Given this list of marker genes BNIP3L, NDRG2, NAPRT, SLC2A6, SLC47A1, EMILIN2 (elastin microfibril interfacer 2), EIF2AK4, HEATR3, CPEB3, CTBP1, ITGAL, HBZ, ASGR2, ADSS1, BIRC3, GPR18, ALDH16A1, PRAM1, EIF4G3, MEF2A, SLC39A11, HBA1, ULK2, FBXO15, MYL4 (myosin light chain 4), ZEB1, SLC25A13 (solute carrier family 25 member 13), SAT2, NANS, SPON2, C8orf82 (NCBI Gene Id 414919), DEFA4, ACKR3, ZSWIM5, DCAF12, TMOD1, HBB, here is a description of the gene set: species: Homo sapiens Genes that are components of a model predictive of response in peripheral blood mononuclear cell 7d vs 0d in adults (18-45) after exposure to YF-17D vaccine, time point 7D. Comment: Suppl Table 4: genes validated by ClaNC as being predictive of CD8+ T cell responses from Fig. 4. from publication Querec TD, Akondy RS, Lee EK, Cao W, Nakaya HI, Teuwen D, Pirani A, Gernert K, Deng J, Marzolf B, Kennedy K, Wu H, Bennouna S, Oluoch H, Miller J, Vencio RZ, Mulligan M, Aderem A, Ahmed R, Pulendran B (PMID 19029902) Human Gene Set: QUEREC_MODEL_PBMC_YF_17D_VACCINE_AGE_18_45_7DY_PREDICTIVE A major challenge in vaccinology is to prospectively determine vaccine efficacy. Here we have used a systems biology approach to identify early gene 'signatures' that predicted immune responses in humans vaccinated with yellow fever vaccine YF-17D. Vaccination induced genes that regulate virus innate sensing and type I interferon production. Computational analyses identified a gene signature, including complement protein C1qB and eukaryotic translation initiation factor 2 alpha kinase 4-an orchestrator of the integrated stress response-that correlated with and predicted YF-17D CD8(+) T cell responses with up to 90% accuracy in an independent, blinded trial. A distinct signature, including B cell growth factor TNFRS17, predicted the neutralizing antibody response with up to 100% accuracy. These data highlight the utility of systems biology approaches in predicting vaccine efficacy.